The following is a description of a gene set: species: Mus musculus Mouse Gene Set: MIR_6897_5P Genes predicted to be targets of miRBase v22 microRNA mmu_miR_6897_5p in miRDB v6.0 with MirTarget v4 prediction scores > 80 (high confidence targets). from publication Chen Y, Wang X (PMID 31504780), and this is the list of marker genes: Dnmbp, Efnb1, Stambp, Rps6kb1, Itga5, Fat3, Cx3cl1, Pdgfb, Pigt, Hspa12b, Dedd2, Spred3, Sec61a2, Vstm2a, Csnk1g1, Iqsec2, Kcnab2, Med7, Hoxc4, Prdm8, Ccnd2, Coq5, Gatad2b, Nod2 (nucleotide-binding oligomerization domain containing 2), Inka2, Ccdc97, Rtbdn, Fyco1, Fbrs (fibrosin), Cilk1, Cplx2, Shisa6, Eloa, Tmem26, Eif5a, Crtc1, Yipf4, Rasgef1a, Klra17, Usp21, Rhog, Ginm1, Serpinc1, Asic1, Tfpi, Ttc28, Ttyh3, Traf1 (TNF receptor-associated factor 1), Gsx1, Dnaaf6, Vamp2, Plppr2, Bak1, Mknk2, Dennd2a, Rhcg, Scn2b, Klf8, Rab5c, Ankrd13b, Sp7, Rad21 (RAD21 cohesin complex component), Mcpt1